The following is a description of a gene set: from publication Chen Y, Wang X (PMID 31504780) species: Mus musculus Mouse Gene Set: MIR_6948_3P_MIR_7117_3P Genes predicted to be targets of miRBase v22 microRNA mmu_miR_6948_3p, mmu_miR_7117_3p in miRDB v6.0 with MirTarget v4 prediction scores > 80 (high confidence targets)., and this is the list of marker genes: B4galt4, Prdm16, Snx5, Barx1, Elk3, Or4n5, Cntnap2, Smim6, Rsph6a, Dlgap2, Ino80d, Ttc19, Chgb, Vav2, Ublcp1, Nr3c2, Kat2b, Reln (reelin), Ubfd1, Cltc, Picalm, Grk3, Zfp775, Phc2, Esrrg, Slc38a4, Npas3, Ccser1, Chic1, Tra2a, Cdh11, Smad5, Kcna6, Cmtm4, Hmg20a, Pctp, Slc28a3, Nnmt, Senp7, Tbc1d14, Zcchc14, Stat5b, Mmd, Slfn8, Cer1, Spag6l, Enpp4, Unc5c, Zhx3, Fbxo22, Slc35a1, Aff1, Syt9, Trim27 (tripartite motif-containing 27), Cog5, Trp53inp1, Lrat, Tspan8, Pabpn1, Prkca, Tgm1, Ripor2, Bicd1, Usp48, Rad17, Tial1 (Tia1 cytotoxic granule-associated RNA binding protein-like 1), Ncor2, Kif7, Slc35d1, Arfip2, Aplnr, S1pr2, Stag2, Grip1, Grb10, Tob1, Zfx, Rims2, Irx1, Chst11, Ereg (epiregulin), Pla2g6, Plcb1, Stxbp6, Eif5a2, Ppm1g, Slc24a2, Slc30a5, Cdon, Efemp2, Baz2b, Ppp1cb, Mgrn1, Septin12, Grhl2, Slc25a25 (solute carrier family 25 (mitochondrial carrier, phosphate carrier), member 25), Lrrc74b, Dclk2, Slc35a5, Ssbp3, Prtg, Arf4, Mospd1, Sirpb1c, Slc7a6, Kazn, Virma, Oaz2, Abcf1, Entrep1, Ptger2, Poln, Rsrc2 (arginine/serine-rich coiled-coil 2), Fbxo33, Phex, Arid1a, Scmh1, Csnk1e, Col16a1, Zbtb41, Naa25, Aopep, Tor1b, Slfn9, Ctdspl2, Ppp3r1, Slc16a9, Fbln5